Given this list of marker genes SLC12A3, CASR, GNA11, CLDN10, ALDOB, CLCNKB, AP2S1, here is a description of the gene set: Hypermagnesemia An abnormally increased magnesium concentration in the blood. studied in species Homo sapiens Human Gene Set: HP_HYPERMAGNESEMIA